Given this list of marker genes SMARCA1, ZRANB3, RAD54L, SMARCAL1, TP53, here is a description of the gene set: studied in species Homo sapiens An ATP-dependent activity that facilitates the formation of a complementary double-stranded DNA molecule. Human Gene Set: GOMF_ATP_DEPENDENT_DNA_DNA_ANNEALING_ACTIVITY